The following is a description of a gene set: from publication Mori S, Rempel RE, Chang JT, Yao G, Lagoo AS, Potti A, Bild A, Nevins JR (PMID 18922927) The Emu-myc transgenic mouse has provided a valuable model for the study of B-cell lymphoma. Making use of gene expression analysis and, in particular, expression signatures of cell signaling pathway activation, we now show that several forms of B lymphoma can be identified in the Emu-myc mice associated with time of tumor onset. Furthermore, one form of Emu-myc tumor with pre-B character is shown to resemble human Burkitt lymphoma, whereas others exhibit more differentiated B-cell characteristics and show similarity with human diffuse large B-cell lymphoma in the pattern of gene expression, as well as oncogenic pathway activation. Importantly, we show that signatures of oncogenic pathway activity provide further dissection of the spectrum of diffuse large B-cell lymphoma, identifying a subset of patients who have very poor prognosis and could benefit from more aggressive or novel therapeutic strategies. Taken together, these studies provide insight into the complexity of the oncogenic process and a novel strategy for dissecting the heterogeneity of B lymphoma. studied in species Mus musculus Human Gene Set: MORI_IMMATURE_B_LYMPHOCYTE_UP Up-regulated genes in the B lymphocyte developmental signature based on expression profiling of lymphomas from the Emu-myc transgenic mice: the immature B stage., and this is the list of marker genes: CD72, TRAF3, MYL12B, SLC25A53, PXK, IL10RA, ADCY7, SELENOW, CTSS, DUSP6, BTG1, GPR65, LIMS1, SCD, SEMA4D, CD83, SAMHD1, CNR2, GUCD1, IFI30 (NCBI Gene Id 126359), CAPN1, PTPRC, DTX1, SMAP2, IGKV1D-43, RHOQ, ERO1B, PTPN6, GNS, ATP6V0B, RGL2, TMEM50B, GGA2, LY6D, PML, RGS14, CAPG, CD74, HLA-DMA, LYN, LAT2, HCK, BIRC3, HLA-DMB, NEAT1, GMIP, MCL1 (MCL1 apoptosis regulator, BCL2 family member), PIP4K2A, MS4A1, JARID2, GPCPD1, IGKV5-2